Given this list of marker genes PRKCSH, MGAT1, CANX, MOGS, GANAB, S, here is a description of the gene set: species: Homo sapiens part of: Translation of Structural Proteins Reactome Pathway: Maturation of spike protein_9683686 Spike protein of SARS-Cov is subject to N-glycosylation and palmitoylation. The chaperone calnexin exclusively helps with protein folding. The end product is a homotrimer.